The following is a description of a gene set: Reactome Pathway: tRNA processing electronically inferred by orthology from the curated human pathway part of: Metabolism of RNA studied in species Mus musculus This event has been computationally inferred from an event that has been demonstrated in another species.<p>The inference is based on the homology mapping from PANTHER. Briefly, reactions for which all involved PhysicalEntities (in input, output and catalyst) have a mapped orthologue/paralogue (for complexes at least 75% of components must have a mapping) are inferred to the other species., and this is the list of marker genes: Yrdc, Qng1